Given this list of marker genes Rpl3, Dach2, Rplp1rt, Cckar, Apc, Nfyc-ps, Hnrnpd, Ybx2, Rnf2, Stk31, Hdac10, Ywhaq-ps2, Tesk2, Gpbp1l1, Acbd6, Ntn4 (NCBI Gene Id 57764), Heg1, Dhx29, Plekho1, Cyp11b1, 4933413L06Rik, Vps37a, Castor2, Gm13132, Gm12251, Ubn2, Tenm2 (teneurin transmembrane protein 2), Zfp212, Rpl21-ps8, Gm24916, Icam1, Plod1, Mir7042, Fancl, Tob1, Marchf7, Dclre1a, Mmp16, Scgb1b21, Pgap6 (post-glycosylphosphatidylinositol attachment to proteins 6), Nphp3, Setd2, Gm18131, Cfap251, Iqcb1, Slc41a2, Krtap19-5 (keratin associated protein 19-5), Gm14585, Itpkc, Cfap69, 4930539M17Rik, Ccr7, Gm13217, Pigx, Dclk1, Gm26255, Drosha, Mir665, Capg, Fbxl8, Prkch, Or52h2 (NCBI Gene Id 259057), Pde7a, Mef2a, Gm13034 (NCBI Gene Id 627585), Acp6, Gm12151, Gm8337, Pard3, Mir218-1, Adgrf5, Car2, C8a, A730094K22Rik, Atp5k-ps4, Gm8177, Gm37201, Tnrc18, Gm10373, Gm26310 (NCBI Gene Id 115486375), Hacd1, Pip4k2a, Trp53bp2, Gm21049, Utp6, Tstd2 (thiosulfate sulfurtransferase (rhodanese)-like domain containing 2), Fggy, Rtn4rl2, Usp9x, Oog4, Gm9898, Nlrc3, Gm13182, Smarcc2, Zfc3h1 (NCBI Gene Id 216345), Lrriq1, Nrxn1, Arhgap28, Igf2bp1, Epb41, Gm10577, Gm5190, Ryr3, Gm4479, A630031M04Rik, Gm7063, Mir540, Gtf2e2, Lbr, Pcolce2, Fbxl3, Snord89, Pex5, Metap1d, Srrm4, Rln1, Gm25410, Camsap2, Qars1, 9430091E24Rik, Cypt12, Ccl28, Gclm, Mir3544, 9230104M06Rik (RIKEN cDNA 9230104M06 gene), Bmpr1b, Srrm2, Eif5 (eukaryotic translation initiation factor 5), Mctp1, Scgb1b26-ps, Zfp750 (zinc finger protein 750), Cd63, Scn9a, Plag1, Gm13453, Tpd52-ps, Gm17101, Scgb1b3, Hspd1-ps3, Atg2a, Epha5, Gm16090, Ric3, Tardbp, Gm24840, Mir7057, A330074H02Rik, A3galt2, Gm17366, Gtf2ird1 (NCBI Gene Id 94276), 1700012B09Rik, Fbxo33, Thop1, Mir1948, Rps27a-ps3, Dmgdh, Gm1070, Gm15032, Ark2n, Tmtc1 (NCBI Gene Id 387314), Slamf1, Mitf, Fcmr, Zfhx4, Abcg2, Malsu1, Gm8641, AI429214, Kmo, Pask, Gm7593, Sp140l2, Gm25268, Cep350, Sowahd, Tmem63b, Rerg, Pikfyve, Gm13292, Snrnp200, Hic2, Trim44 (NCBI Gene Id 80985), Plb1, Dlat, Prss47, Fbxl20, Cdkn2c, Gm13649, N4bp2l1, Mgst1, Klk1b22 (NCBI Gene Id 13646), Top2b, Gm13435, Csmd2, Mfn2, Mir3063, Cnot2, Krtap19-9a, Xpo6, Tmem80, Slc38a3, Thsd7b, Cope, Ctsj, Gm6439, Tle6, Gtsf1, Gm25205, Septin9, Alpl (NCBI Gene Id 11647), Cebpe, Appl2, Bambi-ps1, G630016G05Rik, Caln1, Limch1, Lrif1, Arl14epl, Ugt1a9, Pfkp, Tmem131, Magix, Rps15-ps2 (NCBI Gene Id 633683), Pex1, Fam221a, Fdx1, Mpdz, Gm15403, Gm8228, Atxn7l1os2, Ipo8, Adamtsl1, Nup214, Parg, Slc12a6, Krtap14, Dnai7, Fn1, Morc1 (NCBI Gene Id 17450), Sgce, Psma5-ps, Pbk, Hnrnpk, Anapc5, Tatdn2, Arfgef1, Slc4a3, S100z, Rpl31-ps9, Ier5l, 4930599N23Rik, Colq, Meis2, Gm6418, 9030622O22Rik, Uimc1, Gm31466, 4931406C07Rik, C8b, Cntn2, Paqr6, Ccr5, Gm11780, Gm23925, Gm13600, Tspan9, Lgi2, Cul1, Tpr, Ptprm, Fbxw9, Extl2, Spint5, Adgrb3, Trabd, Gm15495, Smox, Mesp2, Gm14701, 4933438B17Rik, Arid4b, 4930431L21Rik, Gm24298, Coro1a, Ncf2-rs, Mybl1, Clec4b1, Gm25600, Jkamp, Tnfaip2 (tumor necrosis factor, alpha-induced protein 2), Ints9, Ankfn1, Ms4a19, Prom1, Rap1gap, Agps, Rad54b, Atrn, Gm6059, Akr1c19, Frmd8os, Efcab10, Irf8, Slc51a, Pan3, Gm8396, Cnksr2, Anks1b, Hyal5, Cpa6, Slc45a4, Smgc, Prss32, Gmcl1, Srp72, Necab2, Gm13036, Mir6357, Gm18701, Mir370, Phactr2, Efcc1, Rbfox3, Prr5, Trbv19, Atg13, Usp20, C430042M11Rik, Zg16, Ip6k1, Pld5, Dennd3, Map3k7, Ap2a1 (NCBI Gene Id 11771), Gm12058, Plekhh3, Lmo7, Alpk1, 3110040N11Rik, Carns1, Gm22978, Ccdc85a, Bank1, Pde4c, Clstn3, Ccdc9, Fgf5, Gm3786, Gm9710, Gm24879, Amot, Rpl38-ps2, Gm5400, Cdc42se2, Mir129b, Lrrc8c, Mir5124b, 2610011E03Rik, Gm13197, Zbtb38, Fam131b, Rhox2f, Or51k1, Hs3st1, Tsen15, Klhl32, Gm7290, Thsd4, Gm8581, Mast4, Gm13368, Stmn2, Ghrh, Ppfia1, Gm13016, Ednrb, Cand2, Cfap73, Xkr4, Gm38171, Sox5, Itgbl1, Ythdc1, Fam184a, Neb, Gm9801, Hsbp1l1, Gm14639, Btf3-ps14, Gm12865, 4930533P14Rik, Ppp2r2d, Igsf11, Gm26670, Gm11225, Mapk1ip1, Cntn5 (contactin 5), Gm15236, Sfswap, Klhl28, Arpc1a (NCBI Gene Id 80673), Tmem38b, Chrna4, Lrrc1, 1700015C17Rik, Pate1, Ggps1, Fermt2, Cpne4, Fcho1, Zhx1, Mpp4, Lcp1, Gm15627, Celf2, Gm13736, Btbd18, Lsm14a, Bsg, Mir7085, Ppp1r12b, 1700086P04Rik, Icam5, Il15ra, Uso1 (NCBI Gene Id 56041), Bcl10, Olfm3, A730036I17Rik, Bmpr1a, Ppp1r2-ps7, Gm12650, Kcnb2, Gphn, Zfp982 (zinc finger protein 982), Akt2-ps, Gm6341, 2510002D24Rik, Synpo2, Abca16 (NCBI Gene Id 233810), Gbp9, Gm3235, Spag6, Sult3a2, Mtbp, Vwde, Ankrd55, 1700054K02Rik, Prkd3, Gm11723, Pals1, Gm8939, Gm5841, Bnip2, Gm10193, Osbpl1a (oxysterol binding protein-like 1A), Lepr, Or4b1b, Gapvd1, Ddx46, Or6d12, Gm5527, Chchd7, Gcsam, Insrr, Pi4kb, Gm43522, Ncor1, Sgms2, Cd9-ps, A230103J11Rik, Tmem165, Zfp819, Vdr, Zbtb7c, Gimap1, Piwil4, Ccdc180, Rpl31-ps24, Ct45a, Gm12866, Meikin, Chd2, Uckl1, Mrpl13, Rc3h2, Kcnt2, Nxt2, Nedd9, Vezt, Gm24525 (predicted gene, 24525), 8430429K09Rik, Frmd4a, Gabbr1, Gm19744, Ncor2, Crhbp, Ndfip2, Gm19086, Hcn3, 4930589L23Rik, Exosc3, 1700120G11Rik, Wnk2, Gtdc1, 1700082M22Rik (RIKEN cDNA 1700082M22 gene), Apaf1, BC021767, Gm14121, Zfp808, Gpr35, 1700025O08Rik, Dis3l2, Zfp292, Arhgef4, Gm14460, Gm13249, Morc2b, Ccdc68, Ptchd3, Stard9, Por, Stx6, Etv6, here is a description of the gene set: from publication Yevshin I, Sharipov R, Kolmykov S, Kondrakhin Y, Kolpakov F (PMID 30445619) Mouse Gene Set: SIRT1_TARGET_GENES Genes containing one or more binding sites for (Sirt1) in their promoter regions (TSS -1000,+100 bp) as identified by GTRD version 20.06 ChIP-seq harmonization. species: Mus musculus